The following is a description of a gene set: Human Gene Set: GSE3982_BCELL_VS_TH2_DN In the present study we used Affymetrix oligonucleotide microarrays to produce gene transcription profiles for the major leukocyte types in humans. This comprehensive dataset enabled us to not only establish which genes were expressed in each leukocyte type, but also which genes were expressed in each subset after activation. The used of a comprehensive dataset of gene profiles from all the major human leukocyte subsets enabled a novel and powerful means for identification of genes associated with single leukocyte subsets, or different immune paradigms. studied in species Homo sapiens from publication Jeffrey KL, Brummer T, Rolph MS, Liu SM, Callejas NA, Grumont RJ, Gillieron C, Mackay F, Grey S, Camps M, Rommel C, Gerondakis SD, Mackay CR (PMID 16474395) Genes down-regulated in comparison of B cells versus Th2 cells., and this is the list of marker genes: FAP, CEP152 (centrosomal protein 152), DDC, PTTG1, SLC25A31, ZFYVE9, FYN, LRFN4, HLX, GINS2, RBM28, STAP2, PAQR4, SFT2D2, ABHD18, DHFR, MYH10, DLGAP5, MIS18BP1, ACOT9, OR1G1, VANGL1, AKAP12, MEOX1, TMEM106C, BDH1, TRAC, KIF2C, LRP12, HDC, SEPHS2, RAI2, PTGIR, ARHGAP11A, MAP7, ATP9A, ZNF207, CIT, FKBP5, CENPU, DAPK1, GIMAP5, CENPI (NCBI Gene Id 2491), ITK, BUB1B, RRM1, PSMG1, G3BP2, NINJ2, TAP2, HEXA-AS1, TXNRD1, SCLY (selenocysteine lyase), BTG3, MT2A, HSD17B14, SPC25, MYOF, AFAP1, GMEB1, NTAQ1, MRPL42, NAP1L4 (NCBI Gene Id 4676), ZNF334, FIRRM, SEC23B, SLC31A1, HOXB2, CST7, KAZN, DDX6 (DEAD-box helicase 6), PLK1, SEMA4C, KRTAP1-3, HES2, TBC1D4, MRC2, PALLD (NCBI Gene Id 51653), CDK2AP1, KRTAP4-7, CYP1A1, PRORP, KLHL23, CDC123, HILPDA, CLEC4M, HNRNPAB, CCNT1, CDC45, CDC25A, RAB38, CDKN3, MRPL15, HACD1, OTUD7B, TNIK, MAPK11, SFXN1, PAK1IP1, LAIR2, ADAM22, DPP4, CCL20, PITX1, TMSB15A, ACOT7, EDNRA, SEC14L2, MSH6, NASP, INPP4B, ADGRG1, GUCY1A2, ADGRA3, AK2, CBR3, MPP1, PTPN3, EHF, GSTT2, GINS3, CFI, C1orf216, DSG2, ACOT13, AOAH, DEFB126, HPRT1, CKS2, COQ7, HAUS7, GLRA3, XRCC3, WARS2, RAD23B, SEC61A2, UBL4A, SDHB, SLC39A14, FECH, EPAS1, RCN1 (NCBI Gene Id 5954), LIFR, KRTAP1-1, GEM, IL5, FUS, DCBLD2, GSC2, CENPS, PYGL, GSTT1, BAG2, MRPL3, IFT56, ALDH3A2, TMEM70, TRAF1, DHCR24, ZBED2, YES1, FOXM1, UTP11, DIXDC1, SPA17, GPR63, HMMR, GABRD, RPS6KA3, NCS1, BDNF, KRTAP5-9, MAOA, U2AF1 (NCBI Gene Id 7309), BMP1, MFGE8, NDUFB3, JPT1, NCAPG, HRH1, ATP2C2, GATA3, RRM2, YIPF4, TYMS, POGLUT2 (protein O-glucosyltransferase 2), ASF1B, CD28, RNF19A, PSMA5, NFIL3, AGK (NCBI Gene Id 55750), CSNK1A1, PIMREG, SPAG5, ZNF157, BHLHE40, MYB, ANO10